Given this list of marker genes RYR1, CSF2RA, ABCA3, DSP, CFTR, SFTPA1, SFTPC, SCNN1B, MUC5B, RTEL1 (NCBI Gene Id 53593), TERC, TERT, HLA-DRB1, POT1, PARN, CSF2RB, FAM13A, STN1, SCNN1A, SCNN1G, SFTPA2, ATP11A, NKX2-1, DPP9, AGR2, here is a description of the gene set: Crackles Crackles are discontinuous, explosive, and nonmusical adventitious lung sounds normally heard in inspiration and sometimes during expiration. Crackles are usually classified as fine and coarse crackles based on their duration, loudness, pitch, timing in the respiratory cycle, and relationship to coughing and changing body position. species: Homo sapiens Human Gene Set: HP_CRACKLES